Given this list of marker genes TCN2, SUCLG1, AMN, CUBN, PRDX1, CASP10, FASLG, CD320 (CD320 molecule), CBLIF, MMUT, MMADHC, GRM7, GUCY2C, ABCD4, CCND1, ABCD1, MTR, MTRR, MMAA, HLA-DQB1, MTHFD1, SLC19A1, FAS, HLA-DQA1, RNF13, ALDH6A1, LMBRD1, HCFC1, SUCLA2, MMACHC, MMAB, ACSF3, here is a description of the gene set: Abnormality of vitamin B12 metabolism Human Gene Set: HP_ABNORMALITY_OF_VITAMIN_B12_METABOLISM studied in species Homo sapiens